Given this list of marker genes Cck, Sgip1, Mc4r, Slc24a4, Ghsr, Ttc21b, Ghrl, Mtor, Fto, Npsr1, Napepld, Nmu, Dgat1, Lepr, Oprk1, Npy, here is a description of the gene set: Mouse Gene Set: GOBP_REGULATION_OF_EATING_BEHAVIOR Any process that modulates the frequency, rate or extent of eating behavior. species: Mus musculus